The following is a description of a gene set: studied in species Homo sapiens Human Gene Set: GOBP_POSITIVE_REGULATION_OF_AMIDE_METABOLIC_PROCESS Any process that activates or increases the frequency, rate or extent of the chemical reactions and pathways involving amides., and this is the list of marker genes: SIRT3, EFNA1, GSK3A, CCN1, ABCA2, ROCK2, TNF, TNFRSF1A, CSNK1E, CLU, MIR206, SP1, SPHK2, PICALM, IFNG, ZNF750, APOE, ENPP7, SLC2A13, PRKCD, NSMAF, EPHA4, IFNGR1, RELA, LRRTM3, CASP3 (NCBI Gene Id 836), PLA2G6, CHRNA7, GSAP, ABCG1, NFE2L2